The following is a description of a gene set: Cilia are membrane-covered organelles that extend from the surface of eukaryotic cells. Cilia may be motile, such as respiratory cilia) or non-motile (such as the primary cilium) and are distinguished by the structure of their microtubule-based axonemes. The axoneme consists of nine peripheral doublet microtubules, and in the case of many motile cilia, may also contain a pair of central single microtubules. These are referred to as 9+0 or 9+2 axonemes, respectively. Relative to their non-motile counterparts, motile cilia also contain additional structures that contribute to motion, including inner and outer dynein arms, radial spokes and nexin links. Four main types of cilia have been identified in humans: 9+2 motile (such as respiratory cilia), 9+0 motile (nodal cilia), 9+2 non-motile (kinocilium of hair cells) and 9+0 non-motile (primary cilium and photoreceptor cells).<br><br>Cilium biogenesis involves the anchoring of the basal body, a centriole-derived organelle, near the plasma membrane and the subsequent polymerization of the microtubule-based axoneme and extension of the plasma membrane. Although the ciliary membrane is continuous with the plasma membrane, the protein and lipid content of the cilium and the ciliary membrane are distinct from those of the bulk cytoplasm and plasma membrane. This specialized compartment is established and maintained during cilium biogenesis by the formation of a ciliary transition zone, a proteinaceous structure that, with the transition fibres, anchors the basal body to the plasma membrane and acts as a ciliary pore to limit free diffusion from the cytosol to the cilium. Ciliary components are targeted from the secretory system to the ciliary base and subsequently transported to the ciliary tip, where extension of the axoneme occurs, by a motor-driven process called intraflagellar transport (IFT). Anterograde transport of cargo from the ciliary base to the tip of the cilium requires kinesin-2 type motors, while the dynein-2 motor is required for retrograde transport back to the ciliary base. In addition, both anterograde and retrograde transport depend on the IFT complex, a multiprotein assembly consisting of two subcomplexes, IFT A and IFT B. <br><br>The importance of the cilium in signaling and cell biology is highlighted by the wide range of defects and disorders, collectively known as ciliopathies, that arise as the result of mutations in genes encoding components of the ciliary machinery. species: Homo sapiens Reactome Pathway: Cilium Assembly part of: Organelle biogenesis and maintenance, and this is the list of marker genes: EXOC3, BBS12, MKS1, PLK1, TUBA1B, TUBA8, SFI1, DYNLL1, NEDD1, SMO, TTBK2, KIFAP3, IFT43, EXOC7, CEP70, CNTRL, TUBA3C, EXOC4, CEP192, MCHR1, IFT27, AKAP9, CEP162, ODF2, ATAT1, ALMS1 (NCBI Gene Id 7840), DYNLRB1, DCTN2, CSNK1E, CCT4, CEP76, DCTN3, TRAF3IP1, GBF1 (NCBI Gene Id 8729), BBS4, TMEM67, OFD1, IFT46, TUBA1C, CPAP, CDK5RAP2, SSNA1, CEP135, PDE6D, IFT81, TCTN3, IQCB1, CLUAP1, TUBG1, ARF4, ARL6, TUBB4B, PRKACA, EXOC1, CEP57, CEP97, HAUS3, IFT70B, PKD2, CEP290, MAPRE1, BBS1, TUBB8, CEP83, RAB11FIP3, ASAP1, TUBB1, CEP41, KIF3A, CEP89, HAUS6, SCLT1, EXOC8, CCT8, BBS10, MKKS, HAUS1, TUBA3D, PCM1, PPP2R1A, BBS2, WDR35, HAUS7, CETN2, IFT56, TUBB4A, TUBB8B, RHO, DYNC2I2, RAB3IP, CCT5, CCT3, KIF24, CEP78, ARL3, TCTN2, TUBAL3, PAFAH1B1, AHI1, DYNC1H1, TUBB2A, DYNC2H1, HAUS5, WDR19, CEP72, IFT80, B9D2, ACTR1A, TUBB6, B9D1, INPP5E, BBIP1, TUBB3, C2CD3, CDK1, IFT172, YWHAG, HDAC6, CEP152, DYNLT5, TCP1, NDE1, IFT70A, LZTFL1, PKD1, SDCCAG8, TUBA1A, RPGRIP1L, KIF3C, TUBA3E, KIF3B, TCTN1, CEP63, CNGB1, FBF1, TNPO1, SEPTIN2, EXOC6, IFT57, HAUS8, DYNC2LI1, BBS9, IFT52, NINL, CCP110, TTC8, NPHP1 (nephrocystin 1), CEP164, TUBA4A (NCBI Gene Id 93373), NPHP4, IFT140, CLASP1, PLK4, MARK4, HAUS2, DYNLL2, IFT20, HAUS4, KIF17, BBS7, CNGA2, CYS1, CKAP5, YWHAE (tyrosine 3-monooxygenase/tryptophan 5-monooxygenase activation protein epsilon), ARL13B, RAB8A, TTC21B, DYNLRB2, EXOC2, EXOC5, RP2, TMEM216, TRIP11, NPHP3, DYNLT2B, BBS5, CSNK1D, TUBB, NEK2, IFT25, TUBB2B (tubulin beta 2B class IIb, NCBI Gene Id 347733), CC2D2A, DYNC1I2, CEP131, UNC119B, PCNT, IFT74, CEP250, DYNC2I1, IFT122, SSTR3, CCT2, PRKAR2B, IFT22, CEP43, DYNLT2, DCTN1, HSP90AA1, CNGA4, IFT88, RAB11A